The following is a description of a gene set: Inflammatory or noninflammatory diseases affecting the glomeruli of the nephron. Glomerulopathy Human Gene Set: HP_GLOMERULOPATHY studied in species Homo sapiens, and this is the list of marker genes: LMNB2, ERAP1, KCNE5, KLRC4 (NCBI Gene Id 8302), WIPF1, PRTN3, WAS, HLA-DPA1, DNASE1L3, FAS, STAT4, LMX1B, TLR4 (NCBI Gene Id 7099), C4A, APOE, UBAC2, ELP1, HNF1B, FN1, FOXC2, IFNGR1, AMMECR1, LPIN2 (lipin 2), IL12A-AS1, HLA-DPB1, SCARB2, WT1, MMACHC, OCRL, MTRR, PTPN22 (NCBI Gene Id 5779), IL10, CCR1, CTLA4, IL12A, MEFV, LMNA, GLA, HLA-B, ACSL4, IL23R